The following is a description of a gene set: Human Gene Set: HP_ABNORMAL_CIRCULATING_IRON_CONCENTRATION Abnormal circulating iron concentration The concentration of iron in the blood circulation is outside the limits of normal. species: Homo sapiens, and this is the list of marker genes: PKLR, FOXP1, RACGAP1, FTH1, PIGA, HJV, SKIC2, HAMP, KIF23, TFR2, CARD9, STAB1, CP (NCBI Gene Id 1356), SKIC3, TRNT1, HFE, TMPRSS6, STEAP3, SLC11A2, BMP2, BCS1L, FTL, COL7A1